Given this list of marker genes FGFR2, DYNC2LI1, CBFB, ATP7A, B4GALT7, PORCN, BMPR1A, SCARF2, CHD4, XYLT1, LEMD2, RSPO2, ZMPSTE24, LMNA, BCOR, PTEN, TBX3, MSX2, BGN, DCHS1, CDC42BPB, FAT4, HOXD13, FLNA, RUNX2, TWIST1, IDUA, SALL4, NSDHL, ALX4 (NCBI Gene Id 64068), TBX5, FBXL3, SRCAP, NAA10, FIG4, TRIP11, RNU12, here is a description of the gene set: Reduced length of the clavicles. species: Homo sapiens Short clavicles Human Gene Set: HP_SHORT_CLAVICLES